The following is a description of a gene set: species: Mus musculus Covalent attachment of the ubiquitin-like protein NEDD8 (RUB1) to another protein. Mouse Gene Set: GOBP_PROTEIN_NEDDYLATION, and this is the list of marker genes: Dcun1d3, Rbx1-ps, Cdkn2a, Ube2frt, Nae1, Rpl11, Uba3, Dcun1d2, Ube2m, Dcun1d1, Nedd8 (neural precursor cell expressed, developmentally down-regulated gene 8), Ube2f, Hif1a, Cops9, Rnf7l, Epas1, Dcun1d5, Rnf7, Rpl5, Rbx1, Trim40, Dcun1d4, Tes3-ps